The following is a description of a gene set: Mouse Gene Set: REACTOME_UBIQUITIN_MEDIATED_DEGRADATION_OF_PHOSPHORYLATED_CDC25A Ubiquitin Mediated Degradation of Phosphorylated Cdc25A studied in species Mus musculus, and this is the list of marker genes: Psmc1, Psma6, Psma3, Psmd11, Ubb, Psmb2 (proteasome (prosome, macropain) subunit, beta type 2), Cdc25a, Psmd3, Psmb6, Psmd8, Psma2, Rps27a, Psmd2, Psmd1, Psmc3 (NCBI Gene Id 19182), Psmb7, Uba52, Psma7, Psmd13, Psmd14, Psmc6, Psmb4, Psmb1, Psmb3, Psmc5, Psma5, Psmc4, Uba52rt, Psma1, Psma4, Adrm1, Chek2, Ubc, Psmd6, Psmd12, Chek1, Psmd7, Psmb5, Psmc2